Given this list of marker genes Nck1, Cybb, Sgk1, Polr3e, Dcaf17, Fmod, Bmpr2, Zfp46, Cebpz, Sh2b2, Neu3, Mtcl2, Atrx, 5031439G07Rik, Ehd4, Arl5a, Glrx3, Trpm3, Hoxb2, Arhgap15, Rsad1, Commd6, Capn8, Nav1, Rbms3, Pcyt1b, Rbfox1, Mllt11, Cd93, Cdkl3, Ube2d1, Emx2, Gstm7, Dact3, Scn3b, Fez2, Ascl4, Fcho2, Naa20, Prickle2, Col1a2, Foxd4, Slfn14, Abr, Atp6v1a, Lias, Frmpd4, Ube2d3, Ppargc1b, Zbtb21, Osr2, Ap1s1, Frem1, Shisa9, Otud4, Rsbn1, Cpt1a, Atxn7l3, Capn2, Rtn4, Mme (NCBI Gene Id 97098), Hdac3, Asxl2, Sox4, Nlrp6, Tnfrsf11a, Baz2a, Fam131b, Gfap (NCBI Gene Id 14580), Elfn2, Slc24a2, Liph, Gpr173, Cstpp1, Plpp3, Trp53, Shisa6, Vdac3, Elmod2, Erfe, Abcb6, Zfp655, Casd1, Sprr2d, Igfbp5, Zfp704 (NCBI Gene Id 269407), B230219D22Rik, Mecp2, Mab21l2, Akirin1, Trpv6 (NCBI Gene Id 64177), Hoxb9, Mtx3, Btbd16, Gm5878, Cstb, Slc35d2, Prkg2, Gmeb2, Asf1b, Cdc73, Mpp1, Lhx6, Rnf2, Jph1, Crp, Fry, Stac2, Pdlim3, Rab3il1, Dhx16, Hip1, Sema4g, En2, Kif6, Ntng1, Frrs1l, Hsd17b1, Txk, Scmh1, Mrm2, Rp2, Hbp1, Vps13d, Coro2a (NCBI Gene Id 320131), Alkbh5, Crebrf, Tfap4, Scai, Rbbp7, Fosl1, Prickle1, Vcl, Eif1ad8, Lsm12, Pkn2, Rassf7, A2ml1, here is a description of the gene set: Mouse Gene Set: MIR_6983_5P studied in species Mus musculus from publication Chen Y, Wang X (PMID 31504780) Genes predicted to be targets of miRBase v22 microRNA mmu_miR_6983_5p in miRDB v6.0 with MirTarget v4 prediction scores > 80 (high confidence targets).